Given this list of marker genes GIPR, GNG7, GNGT1, SCT, GNG11, GLP2R, ADCYAP1, GNG2, GNB5, GNG13, VIP, VIPR2, GNGT2 (G protein subunit gamma transducin 2, NCBI Gene Id 2793), GNG4, GNG12, GNB4, GNB2, GCGR, GNG5, GNG3, VIPR1, SCTR, GNG8, GNB1, GNG10, GHRH, GCG, GIP, GHRHR, ADCYAP1R1, GLP1R, GNAS, GNB3 (G protein subunit beta 3), here is a description of the gene set: The glucagon hormone family regulates the activity of GPCRs from the secretin receptor subfamily in Class II/B (Mayo KE et al, 2003). Reactome Pathway: Glucagon-type ligand receptors part of: Class B/2 (Secretin family receptors) species: Homo sapiens